Given this list of marker genes SLC13A1, SLC6A6, SLC12A1, SLC6A1, SLC12A2, SLC12A3, SLC12A5, SLC6A13, SLC12A6, SLC6A11, SLC39A14, SLC5A5, SLC18A1, SLC6A12, SLC12A4, SLC6A18, SLC6A3, SLC6A8, SLC12A8, SLC18A2 (solute carrier family 18 member A2), SLC22A1, SLC12A9, SLC12A7, SLC6A4, SLC6A2, here is a description of the gene set: Human Gene Set: GOMF_MONOATOMIC_ANION_MONOATOMIC_CATION_SYMPORTER_ACTIVITY studied in species Homo sapiens Enables the transfer of a solute or solutes from one side of a membrane to the other according to the reaction: anion(out) + cation(out) = anion(in) + cation(in).